The following is a description of a gene set: Genes predicted to be targets of miRBase v22 microRNA hsa-miR-4322 in miRDB v6.0 with MirTarget v4 prediction scores > 80 (high confidence targets). species: Homo sapiens from publication Chen Y, Wang X (PMID 31504780) Human Gene Set: MIR4322, and this is the list of marker genes: FCN1, CLDN10, RAB5C, CERS6, SH3BP1, CBLB, NME6, LOXL3, SPOCK3, EIF3J, APLN, EBF3, SYCE1, PCDH17, ASB7, PRF1, TMEM196, RAD51B, ARID5B, OLFML1 (olfactomedin like 1), VWF (von Willebrand factor), KIAA1549L, STUM (NCBI Gene Id 91267), TNRC6A, VEPH1, CINP, AQP6, ATP6V1B1, MYOF, ETV5, ADGRG6, LRAT, FAF2, RPL28, STXBP5, USP8, RUNX1T1